Given this list of marker genes CFAP70, H2AC8, ESRRG, H1-3, DMXL1, UCHL1, SPMIP4, ABCD2, SAMD5, C5orf22, ACSL6, IGF1 (insulin like growth factor 1), MRNIP, KLHL13, HYCC2, ZNF354B, MAU2, RGS18 (NCBI Gene Id 92122), SNURF, TMEM267, CASP12, DDIT4L, FKBP15, here is a description of the gene set: The mouse aldehyde oxidase AOH2 (aldehyde oxidase homolog 2) is a molybdoflavoenzyme. Harderian glands are the richest source of AOH2, although the protein is detectable also in sebaceous glands, epidermis, and other keratinized epithelia. The levels of AOH2 in the Harderian gland and skin are controlled by genetic background, being maximal in CD1 and C57BL/6 and minimal in DBA/2, CBA, and 129/Sv strains. Testosterone is a negative regulator of AOH2 in Harderian glands. Purified AOH2 oxidizes retinaldehyde into retinoic acid, while it is devoid of pyridoxal-oxidizing activity. Aoh2(-/-) mice, the first aldehyde oxidase knockout animals ever generated, are viable and fertile. The data obtained for this knockout model indicate a significant role of AOH2 in the local synthesis and biodisposition of endogenous retinoids in the Harderian gland and skin. The Harderian gland's transcriptome of knockout mice demonstrates overall downregulation of direct retinoid-dependent genes as well as perturbations in pathways controlling lipid homeostasis and cellular secretion, particularly in sexually immature animals. The skin of knockout mice is characterized by thickening of the epidermis in basal conditions and after UV light exposure. This has correlates in the corresponding transcriptome, which shows enrichment and overall upregulation of genes involved in hypertrophic responses. Genes down-regulated in skin upon knockout of AOX4. Human Gene Set: TERAO_AOX4_TARGETS_SKIN_DN from publication Terao M, Kurosaki M, Barzago MM, Fratelli M, Bagnati R, Bastone A, Giudice C, Scanziani E, Mancuso A, Tiveron C, Garattini E (PMID 18981221) species: Mus musculus